Given this list of marker genes Igfbp3 (NCBI Gene Id 16009), Phip, Myorg, Ghsr (growth hormone secretagogue receptor), Igfbp4, Igf1, Ar, Igfbp5, Ift88, Cdh3, Wnt1, here is a description of the gene set: Mouse Gene Set: GOBP_POSITIVE_REGULATION_OF_INSULIN_LIKE_GROWTH_FACTOR_RECEPTOR_SIGNALING_PATHWAY Any process that increases the frequency, rate or extent of insulin-like growth factor receptor signaling. species: Mus musculus